The following is a description of a gene set: Any process that modulates the frequency, rate or extent of action potential creation, propagation or termination in a ventricular cardiac muscle cell contributing to the regulation of its contraction. This typically occurs via modulation of the activity or expression of voltage-gated ion channels. Human Gene Set: GOBP_REGULATION_OF_VENTRICULAR_CARDIAC_MUSCLE_CELL_ACTION_POTENTIAL studied in species Homo sapiens, and this is the list of marker genes: DLG1, BIN1, TRPM4, JUP, DSG2, RYR2, PKP2, CTNNA3, CAV1, DSP, DSC2, CACNA1C